The following is a description of a gene set: The formation of a large multiprotein-DNA complex that self-assembles on gene promoter through the sequential recruitment of the general initiation factors that compose the preinitiation complex (PIC). The PIC engages the RNA polymerase on its DNA template strand and sparks polymerization of the first few RNA nucleotides. species: Homo sapiens Human Gene Set: GOBP_TRANSCRIPTION_PREINITIATION_COMPLEX_ASSEMBLY, and this is the list of marker genes: MED16, TAF9, TAF3 (NCBI Gene Id 83860), TAF4B, TAF11L4, TAF11L13, RRN3, TAF2, BAZ2A (NCBI Gene Id 23525), CAND1, TBP, UBTFL1, TAF1L, MED26, MED23, TAF6, TAF11L11, TAF11L3, TAF11L6, MED31, MED17, TAF6L, MED6, MED10, TAF11L10, MED4, TAF4, BDP1, SMARCA4, TAF11L9, TP53, TAF7L, TAF11L12, MED11, MED7, MED9, PSMC6, WNT10B, GTF2A2, BRF1, MED30 (NCBI Gene Id 90390), MED28 (mediator complex subunit 28), TAF7, GTF2A1, MED18, TAF5, MED19, TAF13, UBTF, MED29, TAF8, TAF11, GTF2B, MED22, CREB1, MED8, POLR1E, TAF12, TAF1C, MED15, TAF11L7, MED21, UBTFL6 (NCBI Gene Id 648213), MED27, NFKBIZ, TAF11L8, HMGB1, ESR1 (estrogen receptor 1), TAF1, TAF11L14, TAF1B, TAF11L2, DR1, THRA, MED14, TAF10, BRF2 (BRF2 RNA polymerase III transcription initiation factor subunit), SMARCB1, MED24, MED1, MED20, MED25 (NCBI Gene Id 81857)